The following is a description of a gene set: Catalysis of the sequential cleavage of nucleotides (such as mononucleotides or dinucleotides) from a free 5' terminus of a single-stranded DNA molecule. studied in species Mus musculus Mouse Gene Set: GOMF_SINGLE_STRANDED_DNA_5_3_DNA_EXONUCLEASE_ACTIVITY, and this is the list of marker genes: Pld4, Mgme1, Exo5, Pld3, Exo1